Given this list of marker genes GYG1, COLQ, NOTCH3, RRM2B, COL12A1, GFPT1, MAP3K7, CPLX1, ALDOA, FBN1, FUCA1, SMS, SNORD115-1, LETM1, FGFRL1, SNORD116-1, CHRNE, ATP6V1A, HFE, TGFB3, CHST14, PWAR1 (NCBI Gene Id 8122), LIG3, HERC2, ATP6V1E1, FARSA, PANK2, AKT1, SLC9A6, NSD2, G6PC1, AP4E1, DSE (dermatan sulfate epimerase), MAGEL2, PIEZO2, PWRN1, LMX1B (LIM homeobox transcription factor 1 beta), PLOD1 (procollagen-lysine,2-oxoglutarate 5-dioxygenase 1), FSHB, FUZ, ECEL1, HSD17B4, PYCR1, BMP6, ATP6V0A2, NPAP1, STRADA, GRB10, TYMP, B4GALT1, POLG, MKRN3, TRIM2, TBC1D20, RUSC2, MUSK, CTBP1, SPARC (NCBI Gene Id 6678), VANGL1, RAB18, here is a description of the gene set: Human Gene Set: HP_DECREASED_MUSCLE_MASS species: Homo sapiens Decreased muscle mass